The following is a description of a gene set: Human Gene Set: GOMF_K63_LINKED_DEUBIQUITINASE_ACTIVITY species: Homo sapiens Hydrolysis of a ubiquitin unit from a ubiquitinated protein linked via the Lys63 residue of ubiquitin., and this is the list of marker genes: CYLD, OTUD4, STAMBP, USP27X, TNFAIP3, USP54 (ubiquitin specific peptidase 54), USP9X, ATXN3, DESI2 (NCBI Gene Id 51029), PSMD14, STAMBPL1, USP14, USP53, YOD1, OTUD5, USP8, BRCC3